The following is a description of a gene set: Metal ion SLC transporters studied in species Mus musculus Mouse Gene Set: REACTOME_METAL_ION_SLC_TRANSPORTERS, and this is the list of marker genes: Slc31a1, Slc30a8, Slc39a3, Slc39a1, Slc39a7, Slc39a4, Slc11a1, Slc39a2, Slc11a2, Slc41a1, Slc39a8, Slc30a10, Slc39a14, Slc30a1, Heph, Slc39a6, Cp, Slc30a5, Slc41a2, Slc40a1